Given this list of marker genes SPAG6, MNS1 (NCBI Gene Id 55329), DNAH2, SPEF1, NEURL1, IFT56, CC2D2A, CFAP44, DNAAF6, DNAJB13, FBXO24, ZMYND12, DNAAF10, RSPH9, CLUAP1, MEIG1, CFAP206, DNAAF11, PLA2G3, UBE2B, IQCG, CFAP91, CCDC146, DNAAF5, DNAL1, FOXJ1, CFAP43, CPLANE2, CFAP69, OFD1, SPACA9, JHY (NCBI Gene Id 79864), CFAP97D1, LRGUK, SPEF2, CFAP57, CCDC103, DNAI4, CFAP157, DCX, DNAI2, CFAP47, DNAH17, ODAD4, BBOF1, DNAAF2, TTLL8, CFAP74, RSPH1, DNAH8, PIERCE1 (NCBI Gene Id 138162), TTLL1, CCDC40, TBC1D21, TTC12, LRRC23, TEKT2, DAW1, DRC1, RP1L1, FSIP2 (NCBI Gene Id 401024), CFAP73, DNAI3, SPAG16, CFAP100, GAS8, CCDC63, DNAH7, CLXN, CFAP46, RSPH4A, SPAG1, ODAD3, LRRC46, CEP131, CFAP65, ZMYND10, PIERCE2, DNAAF8, ODAD2, BBS2, TTLL5, RP1, DNAI1, TOGARAM1, TTLL3, PDCL2, CFAP58, DNAAF1, DNAH5, CCDC39 (coiled-coil domain 39 molecular ruler complex subunit), DNAAF4, DNAAF3, HYDIN, LRRC61, ODAD1, TPGS1, STK36, DRC7, HOATZ, DNAH1, ARMC2 (NCBI Gene Id 84071), RSPH6A, CCDC65, SPAG17, here is a description of the gene set: studied in species Homo sapiens Human Gene Set: GOBP_AXONEME_ASSEMBLY The assembly and organization of an axoneme, the bundle of microtubules and associated proteins that forms the core of cilia (also called flagella) in eukaryotic cells and is responsible for their movements.